The following is a description of a gene set: studied in species Mus musculus Binding to a stem-loop in an RNA molecule. An RNA stem-loop is a secondary RNA structure consisting of a double-stranded RNA (dsRNA) stem and a terminal loop. Mouse Gene Set: GOMF_RNA_STEM_LOOP_BINDING, and this is the list of marker genes: Csde1, Myh10, D1Pas1, Cpeb3, Dhx9, Ddx56, Mettl16, Eprs1, Eif4a3, Eif4a3l2, Larp6, Zc3h12a, Rc3h1, Rc3h2, Arid5a, Fmr1, Eif4a3l1, Dazap1, Ddx3x